Given this list of marker genes Heca, Tlx3, Suv39h2, Fbxo33, Grm8, Cdk12, Kras, Fam168b, Sar1b, Hnrnpu, Tmem106b, Cyp39a1, Cntnap5b, Myb, Ap1s2, Cpsf6, Nr4a3, Pex7, Ubxn2a, Nfat5, Insm1, Cd226, Ammecr1, Bbc3, Vcpip1, Six1, Dennd6a, Ackr3, Derl2, Vsig1, Dhh, Camk2d, 4921539E11Rik, Zfp703, Skint10, Scel, Tmub2, Sos2, Ctcf, Srsf2, Kifap3, here is a description of the gene set: from publication Chen Y, Wang X (PMID 31504780) Mouse Gene Set: MIR_449A_3P Genes predicted to be targets of miRBase v22 microRNA mmu_miR_449a_3p in miRDB v6.0 with MirTarget v4 prediction scores > 80 (high confidence targets). studied in species Mus musculus